The following is a description of a gene set: studied in species Homo sapiens A process that modulates the formation of a microvillus. Human Gene Set: GOBP_REGULATION_OF_MICROVILLUS_ASSEMBLY, and this is the list of marker genes: ATP8B1, PLD1, FSCN1, PODXL, KLF5, RAP1GAP